The following is a description of a gene set: studied in species Homo sapiens Neighborhood of HDAC2 Neighborhood of HDAC2 histone deacetylase 2 in the MORF expression compendium Human Gene Set: MORF_HDAC2, and this is the list of marker genes: ANXA7, SLBP, DARS1, PTGES3, NELFA, HAT1, XPO7 (exportin 7), SSB, CLNS1A, TCERG1, DDX39A (NCBI Gene Id 95781), AATF, DLD, PRPS2, TM9SF2, CS, CUL1, TFAP4, SNRPA, KHDRBS1, EPRS1, RCHY1, KHSRP, STK24, PRPF31 (NCBI Gene Id 6106), ZMYM4, EI24, PPP2CA, LSM2, RNF44, VDAC3, DRG1 (developmentally regulated GTP binding protein 1), DUT, DFFA, GPAA1, DDX19B, SERP1, TCEA1, ATXN10, HSPA9, FBXW11, MCM2, XRCC5, RBMX, DDX19A, SRSF1, COQ9, CHERP, PRKDC, SOD1, SET, ZPR1, TXNL4A, LYPLA1, PABPC4 (poly(A) binding protein cytoplasmic 4), TFDP1, XPOT, SNRNP200, CNOT3, MSH2, GNG5, PWP1, FAM120A, SON, KXD1, DGUOK, KRIT1, ZWINT, SNRPE, CCT2, TM9SF4, EIF4H, SRP9, SUCLA2, SAFB, CDK11A, ACTR3, UBA2, SEM1, MTX2, CLTC, TOMM70, PDHB, NUFIP1, XPO6, UBE2E1 (NCBI Gene Id 94682), MRPS27, RANBP1, RNF126, CAD, CTDNEP1, RPN1, TARS1, RPA2, POLR2A, DDX18, SSBP1, NSDHL, STARD7, GNB1, AKR7A2, NONO, C6orf62, MCM6, GCN1, DNAJC9, MTCP1, DGKZ, PPP1CC, PMEL, HADHB (hydroxyacyl-CoA dehydrogenase trifunctional multienzyme complex subunit beta), UQCRC2, ZZZ3, MTDH, MTIF2, SRRM1, MTA1, PRKAG1, TXLNA, SGTA, SART3 (spliceosome associated factor 3, U4/U6 recycling protein), METAP1, HSPA8, ZNF131, POLE3 (DNA polymerase epsilon 3, accessory subunit), DDX39B, MDH1, NUP62, ETF1, NSD2, ATP5MC3, RAD54L, G3BP1, NDUFB3, UNG, ACTL6A, SUMO1, PABPN1, ILF2, HNRNPU, RTN4, CDK2, DNAJC8, NDUFAF1, PTDSS1, MMS19, VDAC1, KARS1, RUVBL2, EIF4E, SERBP1, SEC63, ABCF1, HNRNPA2B1, LRPPRC, PRDX3, IFRD1 (NCBI Gene Id 95049), AHSA1, THOC2, RFC4, DDX46, TREX2 (three prime repair exonuclease 2), TARDBP, NNT, MAP2K2, SDHA, GPN1, CEBPZ, CHAF1A, HNRNPAB, TIAL1, SMNDC1 (NCBI Gene Id 10285), U2AF1, BUB1, PAPSS1, PPM1G, DKC1 (NCBI Gene Id 1736), EIF3M, HADH, MLEC, DEK, HNRNPM, MRPL9, HDAC2, ANAPC5, F8A1, CYCS, ACAP2, IDH3G, R3HDM1, AP3S1, HCCS, COPS5, BUB1B, EIF3I, HCFC1, DCTD, YWHAQ, SEC24C, PREP, G3BP2, MFAP1, USP1, NUP188, TNPO3, HMGN4, HSPE1 (NCBI Gene Id 82869), GTF2A2, MAGOH, VDAC2, FH (fumarate hydratase), CCT5, EIF4EBP2, HNRNPR, ESD, ATG12, AFG3L2, VPS26A, BZW1, POLR2C, H2AZ1, FUS, ANP32A, MRPS18B, IMMT (NCBI Gene Id 10989), ATP5PF, RAD21, SDHB, RPA1, YARS1, HDDC2, ATP5PO, SSRP1 (NCBI Gene Id 6749), BAZ1B, TRAPPC3, DNMT1, HNRNPD, VBP1, POLR2I, MTREX, GNL2, ILF3, RAD23A, MARS1, CNBP, PRPF8, ARFGEF1, EDC4, NAE1, RRM1, DNAJC11, PPT1, DOCK3, PSMB2, NCBP2, CAPZA1, ICE1, MCFD2, TUFM, TGDS, NUDC, BMS1, GOT2, HDAC1, XPO1, FIBP, CAMKK2, EIF1AX, GARS1, CCT4 (NCBI Gene Id 10575), EIF2S2, IARS1 (NCBI Gene Id 3376), RNPEP, AIMP2, NDUFV1, NDUFC1, RTCB, BUB3, POM121, ANKRD17 (ankyrin repeat domain 17)